Given this list of marker genes Hoxc4, Psmb7, Nedd8, Hoxa4, Nkx1-2, Npy1r, Prkdc, Ret, Nmb, Eef1g, Hes3, Hcfc1, Papola, Prkcg, Myl4, Ecm1, Taok3, Serpinc1, Reg3g, Ly9, Zkscan5, Fem1b, Gspt1, Flnc, Fabp5, Cp, Neurod4, Dbp, St3gal5, Map2k5, Gdnf, Map3k7, Htr4, Ifna7, Vrk3, Trim10, Uimc1, Gcg, Mpp1, 1700009N14Rik, Ufd1, Inmt, Bmp8b, Hspa8, Ltb, Actc1, Ptprr, Gpx3, Strbp, Mylpf (NCBI Gene Id 67953), Bglap3, Mtnr1a, Fgf11, Rad52, Masp1, Ccl1, Mtor, Cstf2, Nrep, H2-DMa, Wdfy3, Adra2a, Sez6, a, Usp32 (ubiquitin specific peptidase 32), Nr2f1, Cdc20, Col6a1 (NCBI Gene Id 12833), Gli3, here is a description of the gene set: studied in species Mus musculus Downregulated in the neocortex of aged adult mice (30-month) vs young adult (5-month) Mouse Gene Set: LEE_AGING_NEOCORTEX_DN from publication Lee CK, Weindruch R, Prolla TA (PMID 10888876) Ageing of the brain leads to impairments in cognitive and motor skills, and is the major risk factor for several common neurological disorders such as Alzheimer disease (AD) and Parkinson disease (PD). Recent studies suggest that normal brain ageing is associated with subtle morphological and functional alterations in specific neuronal circuits, as opposed to large-scale neuronal loss. In fact, ageing of the central nervous system in diverse mammalian species shares many features, such as atrophy of pyramidal neurons, synaptic atrophy, decrease of striatal dopamine receptors, accumulation of fluorescent pigments, cytoskeletal abnormalities, and reactive astrocytes and microglia. To provide the first global analysis of brain ageing at the molecular level, we used oligonucleotide arrays representing genes to determine the gene-expression profile of the ageing neocortex and cerebellum in mice. Ageing resulted in a gene-expression profile indicative of an inflammatory response, oxidative stress and reduced neurotrophic support in both brain regions. At the transcriptional level, brain ageing in mice displays parallels with human neurodegenerative disorders. Caloric restriction, which retards the ageing process in mammals, selectively attenuated the age-associated induction of genes encoding inflammatory and stress responses.